Given this list of marker genes TTLL1, TTLL5, TTLL2, TPGS1, TTLL9, TTLL11, TTLL13, TTLL6, TTLL7, TTLL4, here is a description of the gene set: Catalysis of the posttranslational transfer of one or more glutamate residues to a specific residue on a target protein. Human Gene Set: GOMF_PROTEIN_GLUTAMIC_ACID_LIGASE_ACTIVITY species: Homo sapiens